The following is a description of a gene set: Mouse Gene Set: CUI_CDC1_IL10_RESPONSE_UP from publication Cui A, Huang T, Li S, Ma A, Pérez JL, Sander C, Keskin DB, Wu CJ, Fraenkel E, Hacohen N (PMID 38057668) Cytokines mediate cell-cell communication in the immune system and represent important therapeutic targets. A myriad of studies have highlighted their central role in immune function, yet we lack a global view of the cellular responses of each immune cell type to each cytokine. To address this gap, the authors created the Immune Dictionary, a compendium of single-cell transcriptomic profiles of more than 17 immune cell types in response to each of 86 cytokines (>1,400 cytokine-cell type combinations) in mouse lymph nodes in vivo. A cytokine-centric view of the dictionary revealed that most cytokines induce highly cell-type-specific responses. For example, the inflammatory cytokine interleukin-1β induces distinct gene programmes in almost every cell type. A cell-type-centric view of the dictionary identified more than 66 cytokine-driven cellular polarization states across immune cell types, including previously uncharacterized states such as an interleukin-18-induced polyfunctional natural killer cell state. Genes positively differentially expressed in cell type: cDC1 (conventional dendritic cell type 1) upon treatment with cytokine: IL-10 in mouse lymph nodes in vivo. species: Mus musculus, and this is the list of marker genes: Shc1, Jarid2, Smdt1, Rrbp1, Timm10b, Myd88, Pim1, Cltb, Grb2, Calr, Syngr2, Cpne2, Dnaja1, Flot1, Pou2f2, Plac8, Mbd2, Scand1, Epn1, Psmb5, Macroh2a1, Cxcl16, Ccdc86, Pdia3, Hnrnpd, Cd300a, Tmem214, Hspa5, Ifitm2, Ifi205, Calm1, Ccnd3, Ctss, Wfdc17, Lamp2, Spi1, Morf4l1, Ptpn1, Mrpl42, Zdhhc23, Bcl3, Socs3, Fth1, Ece1, Sri, Atp6v0a2, Ahr, Plekho1, Fus, Btla, Kmo, Marchf1, Fgr, Itm2c, Tspo, Stip1, Adpgk, Sting1, Bin2, Reep5, Cd24a, Dynll1, Pfn1, Tax1bp1, Ptprc, Esyt1, Ldha, Dad1, Manf, Il1b, Pnp, Naaa, Il4ra, Set, Elob, Anpep, Itga6, Cycs (cytochrome c, somatic), Snrpd3, Gabarapl2, Atp8a1, Ciita, Casp6, Basp1, Skap2, Polr2f, Baz1a, Gatm, Cdk2ap2 (cyclin dependent kinase 2 associated protein 2), Psma7, Olfm1, H2az1